The following is a description of a gene set: from publication Croonquist PA, Linden MA, Zhao F, Van Ness BG (PMID 12791645) Genes up-regulated in the ANBL-6 cell line (multiple myeloma, MM) after withdrawal of IL6. studied in species Homo sapiens Human Gene Set: CROONQUIST_IL6_DEPRIVATION_UP ANBL-6, a myeloma cell line, proliferates in response to interleukin 6 (IL-6) stimulation, coculture with bone marrow stromal cells, and when harboring a constitutively active mutant N-ras gene. Eighteen samples, including 4 IL-6-treated, 3 mutant N-ras-transfected, 3 normal stroma-stimulated, 2 multiple myeloma (MM) stroma-stimulated, and 6 untreated controls were profiled using microarrays interrogating genes. Global hierarchical clustering analysis distinguished at least 6 unique expression signatures. Notably, the different stimuli altered distinct functional gene programs. Class comparison analysis (P =.001) revealed genes (54% involved in cell cycle) that distinguished IL-6-stimulated versus nontreated samples. Eighty-seven genes distinguished stroma-stimulated versus IL-6-treated samples (22% encoded for extracellular matrix proteins). A total of genes distinguished N-ras transfectants versus IL-6-treated samples (26% involved in metabolism). A total of genes, 20% of these involved in signaling, distinguished N-ras from stroma-interacting samples. All 3 stimuli shared genes, mostly of metabolic function. Genes that distinguished MM1 from MM4 clinical groups were induced at least by one treatment. Notably, only genes (ETV5, DUSP6, and KIAA0735) are uniquely induced in mutant ras-containing cells. We have demonstrated gene expression patterns in myeloma cells that distinguish an intrinsic genetic transformation event and patterns derived from both soluble factors and cell contacts in the bone marrow microenvironment., and this is the list of marker genes: ARL4C, HOMER3, FCER2, APOL1, TBC1D9, RAPGEF3, SCGB2A2, BMP2, PDE1A, CDKN1C, LEFTY2, PCDHGA8, FCGRT, SLC7A7, AHNAK, NCF2, ECM2